The following is a description of a gene set: Human Gene Set: REACTOME_METABOLISM_OF_NUCLEOTIDES studied in species Homo sapiens Metabolism of nucleotides, and this is the list of marker genes: GMPR, ITPA, GDA, UCKL1, NUDT5, DNPH1, ATIC, DHODH, APRT, PFAS, CTPS1, UCK1, ADSS2 (adenylosuccinate synthase 2), PUDP, DUT, NT5C1A, NME1, UCK2, GUK1, PAICS, AGXT2, MAPDA, DCTPP1, ENTPD8, TXN, AK5, NUDT1, RRM2B, AK4 (adenylate kinase 4), NT5C3A, ENTPD4, AMPD1, RRM2, DTYMK, GSR, HPRT1, AK8, XDH, CTPS2, RRM1, NT5C2, AK1, AK7, CMPK1 (cytidine/uridine monophosphate kinase 1), GMPS, ENTPD7 (ectonucleoside triphosphate diphosphohydrolase 7), ENTPD5, ADPRM, UMPS, NME3, DPYD, TK1, TK2, ENTPD6, ENTPD3, NUDT16, ENTPD2, ENTPD1, SAMHD1, CDA, IMPDH2, GLRX, AK6, ADSS1 (NCBI Gene Id 122622), NUDT9, AMPD3, TYMS, ADK, ADA, UPP2, UPP1, NME2, PPAT, DPYS, CAD, NT5C1B, DCK, DGUOK, DCTD, ADSL, NUDT15, NUDT13, PNP, GART, IMPDH1, TXNRD1, NT5C, NME4, AK2, AK9, NT5M, TYMP, NUDT18, GMPR2, UPB1, AMPD2, NT5E